The following is a description of a gene set: Binding to heparan sulfate. Human Gene Set: GOMF_HEPARAN_SULFATE_BINDING species: Homo sapiens, and this is the list of marker genes: NRTN, APP, FURIN, GFRA2, MDK, TNFRSF11B, PPIA, DMBT1